The following is a description of a gene set: Any process that modulates the propensity of mitochondrial mRNA molecules to degradation. Includes processes that both stabilize and destabilize mitochondrial mRNAs. studied in species Homo sapiens Human Gene Set: GOBP_REGULATION_OF_MITOCHONDRIAL_MRNA_STABILITY, and this is the list of marker genes: TBRG4, FASTKD2, PDE12, FASTKD3, FASTKD5, FASTKD1, FASTK